The following is a description of a gene set: studied in species Homo sapiens Human Gene Set: DACOSTA_UV_RESPONSE_VIA_ERCC3_COMMON_UP from publication da Costa RM, Riou L, Paquola A, Menck CF, Sarasin A (PMID 15608684) Common up-regulated transcripts in fibroblasts expressing either XP/CS or TDD mutant forms of ERCC3, after UVC irradiation. Xeroderma pigmentosum (XP) and trichothiodystrophy (TTD) syndromes are characterized by deficiency in nucleotide excision repair pathway, but with distinguished clinical manifestations. While XP patients exhibit a high frequency of skin cancer, TTD patients are not cancer prone. The relation between lack of DNA repair and their clinical manifestations was investigated through analysis of the transcriptional profile of 12,600 transcripts in two isogenic cell lines with different capabilities of DNA repair. These cell lines result from a stable transfection of the XPB-TTD allele into XP complementation group B fibroblasts, from an XP patient who also have clinical abnormalities corresponding to Cockayne's syndrome (CS). The microarray assays performed under normal growth conditions showed the expression of distinct groups of genes in each cell line. The UVC-transcription modulation of these cells revealed the changes in 869 transcripts. Some of these transcripts had similar modulation pattern in both cells, although with eventually different time patterns for induction or repression. However, some different 'UVC signature' for each cell line was also found, that is, transcripts that were specifically UV regulated depending on the DNA repair status of the cell. These results provide a detailed portrait of expression profiles that may potentially unravel the causes of the different phenotypes of XP/CS and TTD patients., and this is the list of marker genes: NSUN5P2, RFC5, ACYP1 (NCBI Gene Id 97), TMEM109, CBR1, SHOX2, SYF2, ACOT2, PLPBP, SELENOW, NXF1, TPM2 (tropomyosin 2), TUBA4A, TK1, LIN37, CNP, CTSV, ZNF263, CEP68, DNAL4, HLA-E, FGFR3, TBCC, FAM8A1, CCNE2, GABARAPL1, HEXIM1, HRAS, TUBB4B, NAT1, MICB, SLC6A8, GNS, RELA, CDC34, CEBPD, RPS6KB2, GPRC5B, PCNA, CLTB, SRM, H2AC18, RGS2 (regulator of G protein signaling 2), TREX1, CDC6, RNF103 (NCBI Gene Id 7844), BTG1, EFNA1, RSL1D1, TP53I3, EIF2S3 (eukaryotic translation initiation factor 2 subunit gamma), TSPYL2, DGAT1, HLA-F, CLK3, PIM2, NEU1, ERCC5, CDKN1C, ALAS1, GLUL, KCNJ4, ATF3, ABCB6, ACAA1, TPBG, LHX2, SLC30A3, RHOB, TOB1, TNFSF9, BRD2, OSR2, PNRC1, TFAM